Given this list of marker genes Wipi2, Atg2b, Atg2a (autophagy related 2A), Rb1cc1, Atg12, Stbd1 (NCBI Gene Id 68256), Wipi1, Wdr45b (WD repeat domain 45B), Gaa, Wdr45, Atg3, Gabarapl1, here is a description of the gene set: species: Mus musculus The selective degradation of glycogen by macroautophagy. Mouse Gene Set: GOBP_GLYCOPHAGY